The following is a description of a gene set: species: Mus musculus Mouse Gene Set: MIR_669E_3P Genes predicted to be targets of miRBase v22 microRNA mmu_miR_669e_3p in miRDB v6.0 with MirTarget v4 prediction scores > 80 (high confidence targets). from publication Chen Y, Wang X (PMID 31504780), and this is the list of marker genes: Ptbp3, Slc44a4, Sumf1, Znrf3, Bbs5, Pum2, Ice1, Mbd4, Dipk1a, Arhgap19, Zfp568, En2, Fgfr2, Slc22a1, Ubtfl1, Osbpl8 (oxysterol binding protein-like 8), Or5m3b, Pigq, Hnrnph3, Ky, Cited2, Pde9a, Trim12c, Rad23a, Hsf2, Erc2, Ptprm, Vstm2a, Kcnj15, Bag5, Phf21b, Hlf, Rapgef4, Flrt2, Xkr4, Dspp, Pik3c2a, Catspere2, Cntn4, Cacna2d1, Luc7l2, Abce1, Bloc1s4, Krtap16-3, Cyth3, Cavin4, Epm2aip1, Fut11, Gad1, 9330159F19Rik, Rpl23 (NCBI Gene Id 80497), Scai, Mbd2, Pdzrn4, Nadk2, Dync1i2, Mdh1, Ms4a4b, Edn1 (endothelin 1), Snx3, Ing3, Eda2r, Exph5, Trappc8, Matn1, Pdcd7, Slc30a4, Arhgap21, Phf3, Gpm6b, Lhcgr, Tmt1a2, Irs4, Trappc3, Dlg3, Pira12, Tnfrsf11b, Manea, Timm21, Pcsk5, Arhgap6, Gabrg1, Hus1b, Cpsf6, Pira2, Rnft1, Tex16 (NCBI Gene Id 83556), Ndnf, Adam1b, Zbtb44, Gca, Tab2, Haus2, Mab21l1, Col11a1, Vtcn1, Pgm3, Klhl7, Esp34, Birc3, Poglut3, Fut9, Cab39l, Zdbf2, Csrnp3, Armcx3, Mysm1, Hprt1, Gins2, Krcc1, Hspa1b, Ciao2b, Crem, Cnmd, Uhrf2, Picalm, Mettl6, Ccnt2, Serp1, Kansl1, Adgre4, Htr7 (5-hydroxytryptamine (serotonin) receptor 7), Bmpr2, Spag1, Cspg4, Avl9, Rmnd5b, Kcna4, Cacna1c, F13b, Nup35, Pdp1, Pln, Ripor1, Ank2, Tmem64, Fgf13, Rarres1, Btaf1 (NCBI Gene Id 208902), Rab3c, Zfand4, Bzw1, Elf2, Arfgef3, Katnbl1, Rngtt, Me3, Homer1, Lrch3, Prkaa2, Cdk19, Sgk3, Trps1, Pir, Marchf7, Ptprg, Cebpd, Sfrp2, Rpp30, Hook3, Cdc123, Eif4a2, Lhfpl6, Nexmif, Cacng5, Vkorc1l1, Nxph2, Hopx, Zdhhc21, Nalcn, Akap6, Lamtor1, Zfp958, Galnt6, Wnt3, Pdzrn3, Nectin3, Adamts6, Zfp141, Tmem67, Tpgs2, Nptn, Dmtf1, Kynu, Ncoa2, Elk3, Fam222a, Ube2d1, Thsd7a, Kmt5a, Prlr, Chmp4b, Dip2c, Efr3a, Tbc1d32, Zfp280c, Efcab14, Lnpep, LTO1, Pou4f2, Sox7, Acsl4 (NCBI Gene Id 50790), Nxpe4, Kcnc4, Canx, Gng12, Gucy1a2, Tbl1xr1, Fndc3b, Slc9a9, Trappc13, Sri, Cd2ap